Given this list of marker genes RFC5, MLH1, PMS2, POLE2, POLE4, POLD4, RFC2, POLE, RFC4, RPA2, RPA3, LIG1, RPA1, RFC3, POLD2 (DNA polymerase delta 2, accessory subunit), MSH6, MLH3, MSH2, EXO1, POLE3 (DNA polymerase epsilon 3, accessory subunit), RFC1, POLD3, POLD1, PMS1, MSH3, PCNA, here is a description of the gene set: Mismatch repair. Pathway ID: N01432. Pathway type: Reference. Pathway class: nt06503 Mismatch repair. Pathway Definition from KEGG: (MSH2+MSH6,MSH3) == (MLH1+PMS2,PMS1,MLH3) == PCNA == RFC -> RPA == EXO1 -> POLD,POLE -> LIG1 species: Homo sapiens Human Gene Set: KEGG_MEDICUS_REFERENCE_MISMATCH_REPAIR